The following is a description of a gene set: Human Gene Set: GOBP_REGULATION_OF_ANTIMICROBIAL_HUMORAL_RESPONSE Any process that modulates the frequency, rate, or extent of an antimicrobial humoral response. species: Homo sapiens, and this is the list of marker genes: KLK5 (kallikrein related peptidase 5), GATA6, PGC, IL17F, SPINK5, KLK3, KLK7, PPP2R3C, IL17A, EVPL, ACOD1